Given this list of marker genes B4galt1, Xpo7, Arhgdia, Klc1, Seh1l, Garem1, Hoxa10, Kif1b, Kif1c, Phactr2, Raf1, Epha7 (NCBI Gene Id 13841), Anks1, Ago1, Adgrl2, Nlrx1, Nufip2, Arfgap2, Med26, Prkar2a, Pnp2 (NCBI Gene Id 667034), Rbm6, Gpatch8, Fgf9, Islr, Rarb, Nup210, Trp53inp2, Zc2hc1a, Unc80, Nup50, Il10ra, Sall4, Nfe2l1, Prdm4, Nav1, Usp12, Cdc37l1 (cell division cycle 37-like 1), Actr2, Tbpl1, Cdk17, Eda, Iars1, Zfp449, Pacsin2, Ubn2, Erc2, Wnt7a, Gm5460, Etnk1, Tmcc1, Plpp1, Dcaf7, Spag7, Vegfa, Zbtb39, Kl, Tll1, Aff4, Akap7, G0s2, Pdxk, Peli3, Nynrin, Ube2q1, Mmd, Capn6, Pam, Zcchc3, Ppp6c (protein phosphatase 6, catalytic subunit), Hus1, Mybl1, Pappa (pregnancy-associated plasma protein A), Traf3, Wipi2, Ubfd1, Lrp6, Tuba4a, Slc4a4, Wwp1, Csrnp1, Sesn1, Kif5c, Stradb, Ist1, Zfp367, Pappa2, Cacul1, Hmga1, Phf20, Sptbn2, Acvr2b, Rad9a, Rab11fip1, Ccdc6, Nudt7, Adissp, Plekhm3, Btg2, Reck, Hectd4, Ttll6, Sec24a, Hephl1, Klc4, Septin2, Casr, Slc4a7, Arhgap12, Ghr, Usp14, Chpt1, Ptprr, Abtb2, Ankrd46, Ptpn3, Plxna4, Bicd1, Gpr63, Gbp2b, Dync1li2, Myb, Usp15, Scoc, Fgf7, Rab9b, Kctd8, Adrb2, Bmpr1a, Apln, Reln, Slc6a11, Tbl1xr1 (NCBI Gene Id 99912), Ppm1d, Selenoi, Sgk1, Adamts3, Tmem74b, Nfatc3, Penk, Rubcnl, Dixdc1, Kcnn4, Usp25, Lrig1, Tmem178b, Atf6, Mfn2, Akt3, Rfc1, Lats1, Fasn, Sik1, Sec14l1, Sec61a1 (NCBI Gene Id 53976), Zswim3, Cbx6, Desi1, Btbd8, Sez6l, Kmt2a, Zfp773, Syde2, Krtap26-1, Shoc2, Rere, Cobll1, Avl9, Amotl1, Cd2ap, Smad7, Ywhah, Wnt3a, Arl2, Tab3, Cmpk1, Plagl1, Rasef, Ccdc85b, Ncapg2, Sall1, Kpna1, Pafah1b1, Wee1, Son, Cdca4, Smim13, Igf2r, 6430571L13Rik, Cpd, Med1, Nrbp1, Rfx3, Kcnj2, Caprin1, Ano3, Htr4, Capns1, Ago4, Phc3, Wnk3 (WNK lysine deficient protein kinase 3), Extl3, Slc25a37, Tbp, Cldn12, B3gnt6, Sel1l3, Trabd2b, Tlk1, Fbln5, Cdk12, Colq, Ccnt2, Ube4b, Atxn1l (NCBI Gene Id 78838), Tnrc6b, Eif3a, Kif21a, Ret, Tfap2a, Map2k1, Axin2, Ezh1, Rreb1, Tcaim, Ubr3, Plxnc1, Kcnq5 (potassium voltage-gated channel, subfamily Q, member 5), Wfs1, Ythdc1, Col12a1, Nrn1, Chd2, Luzp1, Cacna2d1, Klhl2, Angel1, Slc20a2, Ddx3x, Ccnjl, Ints6l, Bace1, Fermt2, Fbxw7, Wbp11, Phip, Myt1l, Abhd13, Sox6, Ankrd13b, Zfp275 (zinc finger protein 275), Ppp1r11, Cbx4, Crebrf, Erlin2, Rnf10, Pskh1, Eya1, Znrf2, Rnf217, Krtap11-1, Atp1b4, Slitrk6, Mob3b, Rubcn, Polr3f, Zfhx3, Cpsf7, Itpr1 (NCBI Gene Id 18544), Aar2, Chac1 (NCBI Gene Id 69065), Cyp26b1, Cfap45, Ahcyl2, Nuak2, Rasgef1b, Ash1l, Acox1, Zfhx4, Pnpla6, E2f3, Mapkap1, Cdk5r1, Pik3r1, Man2a2, Kif23, Qki, Dclk1, Abl2, Pip4p2, Suco, Trank1, Zfp300, Ppm1e (NCBI Gene Id 327991), Dcp1a, Acsl4, Jarid2, Entpd7, Armh4, Tacc1, Sema3a, Ccnd2, Onecut2, Kbtbd2, Cpeb2, Slit2, Zbtb34, Gcc2, Atxn2, Lrig2, Cbfa2t3, Kif5b, Gm12886, Plxna2 (plexin A2), Hectd1, Grm7, Lurap1l, Usp42, Spryd3, Mex3c, Rad23b, Rictor, Tenm2, Atp2b2 (NCBI Gene Id 22426), Insyn2a, Tmem135, Cc2d1b, Ccne1, Pwwp2b, Fam151b, Kdsr, Tgfbr3, Kcnk10, Slc4a8 (solute carrier family 4 (anion exchanger), member 8), Setd3, Ppp2r1b, Pnoc, Bcl2, Clspn, Pla2g15, Spred1, Pex13, Cops7b, Rspo3, Fam135a, 1700025G04Rik, Fbxo21, Helz, Pou2f1, Slc25a22, Lhx3, Cert1, Atg14, Nol4l, Pth, N4bp1, Cntnap1, Usp31, Stxbp3 (syntaxin binding protein 3), Tmem87b, Il7r, Clock, Nudt4 (nudix hydrolase 4), Lrrc32, Prmt6, Mgat4a, Zbtb44, Adgrl1, Hapstr1, Idh3a, Rnf144b, Zmym2, Ccr2, Prrc2c, Atp7a (NCBI Gene Id 51824), Armcx6, Plcxd2, Acvr2a, Drd1, Mob4, Crebl2, Ptpn4, Zyx, Akap11, Srpra, Rab10, Ski, Arih1, Pip4p1, Btrc, Dll1 (delta like canonical Notch ligand 1), Cnot6l, E2f7, Slc39a10, Dnajc16, Zfp809, Cpeb3, Satb2, Ell, Cdc25a, Plekhh1 (pleckstrin homology domain containing, family H (with MyTH4 domain) member 1), Chek1, Ippk, Nos1, Spsb4, Socs6, Omg, 2810459M11Rik, Ncs1, Pom121, Bcl2l2, Smurf1, Dsel (dermatan sulfate epimerase-like), Sema6d, Dennd10, Fmn2, Slc7a2, Atxn7l3, Zfp622 (NCBI Gene Id 68674), Slc13a3, Nectin1, Dll4, Phf19, Higd1a, here is a description of the gene set: studied in species Mus musculus from publication Chen Y, Wang X (PMID 31504780) Mouse Gene Set: MIR_16_5P Genes predicted to be targets of miRBase v22 microRNA mmu_miR_16_5p in miRDB v6.0 with MirTarget v4 prediction scores > 80 (high confidence targets).